Given this list of marker genes RIPK3 (NCBI Gene Id 11035), CHUK (NCBI Gene Id 1147), RIPK1, TLR3, BIRC2, RPS27A, UBA52, UBE2D1, UBE2D2, BIRC3 (baculoviral IAP repeat containing 3), UBB, IKBKG, IKBKB, TRAF6, UBE2D3, TICAM1, UBE2N, UBE2V1, UBC, here is a description of the gene set: TICAM1, RIP1-mediated IKK complex recruitment Human Gene Set: REACTOME_TICAM1_RIP1_MEDIATED_IKK_COMPLEX_RECRUITMENT studied in species Homo sapiens